The following is a description of a gene set: Genes predicted to be targets of miRBase v22 microRNA mmu_miR_6418_3p in miRDB v6.0 with MirTarget v4 prediction scores > 80 (high confidence targets). Mouse Gene Set: MIR_6418_3P species: Mus musculus from publication Chen Y, Wang X (PMID 31504780), and this is the list of marker genes: Acadsb, Ugt2a3, Cdkl4, Rnf34, U2surp, Arhgap11a, Arid4a (AT-rich interaction domain 4A), Kcnt2, Aard, Shoc2, Rnf138, Erlin2, Rc3h1, Kif16b, Thap11, Khdrbs1, Lipo1 (NCBI Gene Id 329055), Camk2n1, Kdm5b, Ntaq1, Gm8978, Fam117a, Srsf10, Pakap, Or7a38, Zfp91, Peli1, Epha2, Zfpm2, Cdkn2aip, Meox1 (NCBI Gene Id 17285), Asap2, Unc13c, Ankrd27, Cpeb3, Nfat5, Srpk2 (serine/arginine-rich protein specific kinase 2), Trib2, Uck1, Hectd1, Endod1, Tmem260, Cntnap1 (NCBI Gene Id 53321), Fgf14, Taok3, Taf11, Krtap16-3, Slc25a46, Mgat2, Chpt1, Lct, Hspa4l, Snip1, Ufm1, Frmd4a (NCBI Gene Id 99027), Ogt, Lonrf1, Kcnj2, Rap2c, Ctr9, Med13, Btrc, Col5a1, Hoxb4, Foxn2, Lmo7, Smim15